Given this list of marker genes PPOX, DLL1, ATP1A3, SEMA3D, FXN, CYB561, SNAI2, AKAP9, RAD21, CPLANE1, NTRK1, SREBF1, TSPYL1, DNAJC6, CEP104, ARVCF, RFWD3, FANCG, LGI1, MMEL1, SMC1A, DBH, FOXH1, TNFSF15, BBS2 (NCBI Gene Id 583), MYO1H, FANCF, CAV1, DEPDC5, SLC6A8, UFD1, COL5A1, ERCC4, TBX1, KCNQ1, CCDC28B, RELN, SNCAIP, TGIF1, PINK1 (PTEN induced kinase 1), ALK, DHCR7, GNB2, PLA2G6, GAS1, BRIP1, SCN11A, WFS1, CEP41, ERBB2 (NCBI Gene Id 2064), TYR, HYLS1, RAD51, GABBR2, PAX3, LRRK2, ATXN2, TRIM32, GFAP, CYP11B2, TBX5, TXN2, SCN5A, CCT5, SUFU, PIGY, VPS11, CISD2, FGF8, MYCN, TOGARAM1, KCNH2, PODXL, IL12RB1, SMO, EDNRB, PIBF1, DDX3X, INPP5E, BBS7, BDNF, PIGL, SCLT1, TCTN3, BCOR, SH2B1, CRIPTO, SLC18A2, SPG11, IRF5, FANCI, CALM1 (calmodulin 1), FANCC, BRCA2, TTR, PLCH1, TMEM138, UBE2T, OFD1, SDCCAG8, KIT, TMEM237, MAD2L2, STAG2, COMT, RREB1, RPGRIP1L, SEMA3C, CDON, PRNP, PDE6D, ATXN3, ERBB3, EIF4G1, GSN, NPHP1, SAA1, SPTLC2, RET, CEP290, SOX10, L1CAM, SALL4, CHCHD2, TMEM67, PRKN, ATXN8OS, GBA1, ARL13B, ARX, LMO1, LZTFL1, IFT172, IL12A, TRDN, SEC24C, MAPT, KITLG, ZNF423, KIAA0753, LMNB1, SCN3A, TMEM218, RFC1, CACNA1C, PGAP3, CAV3, HEXB, APC2, POLR3A, KIF1B, FOXF1, ASCL1, NOS1AP, KCNJ5, AAAS, ADH1C, WDR45, MT-TT, ABCD1, DDX59, FBXO7, MBTPS2, IFT74, HACE1, SHH, CSPP1, TUBB3, BBS1, BBS9, KCNE1, TCTN1 (tectonic family member 1), GLI2, ECE1, PARK7, COQ2, SF3B4, HIRA, ARSA, EDN3, DISP1, SCN9A, B9D2, CFAP418, KIFBP, ATL1, FGFR1, GBE1, NODAL, ACBD6, ARL6, COL1A1, B9D1, SLC6A2, TUBA1A (tubulin alpha 1a), SYNE1, SLX4, NAA10, GDNF, PHOX2B, NR4A2, STIL, SETBP1, ATL3 (NCBI Gene Id 283241), CALM2, CACNA1A, JMJD1C, FANCB, SYNJ1, ACTG2, CEP120, PTCH1, FANCM, SLC1A3, BBIP1, PIGW, ELP1, KCNE2, SCN10A, CHRNA3, VPS35, SCN4B, BBS12 (NCBI Gene Id 166379), ANK2, ATP1A2, TMEM231, BBS5, TWNK, MKS1, CBY1, MECP2 (methyl-CpG binding protein 2), LBX1, FANCA, WDPCP (WD repeat containing planar cell polarity effector), GLA, LEP, SIX3 (NCBI Gene Id 6496), ZEB2, ACOX1, CALM3 (calmodulin 3), FANCE, TTC8, ARL3, TCF4, IFT27, CC2D2A, SNTA1, GP1BB, TBP, XRCC2, PIGV, RMRP, AHI1, NRTN, POU2AF1, SPTLC1, PIGO, PGAP2, GCK, GMPPA, KIAA0586, LIN28B, VPS13C, RAD51C, SPIB, LEPR, PALB2 (partner and localizer of BRCA2), ZIC2, CEP19, KATNIP, BRCA1, FANCD2, BRAT1, ATP7A, TCTN2, KRAS, SIM1 (NCBI Gene Id 6492), ATRX, FMR1, PIGN, ARMC9, VPS13A, MITF, B2M, GIGYF2, MKKS, FANCL, DNAJC13, PSAP, BBS4, TNPO3, SNCA, UCHL1, HTRA2, BBS10, SCAPER, CRELD1, LIFR, NSD1, COL5A2, TMEM216, here is a description of the gene set: Human Gene Set: HP_ABNORMALITY_OF_THE_AUTONOMIC_NERVOUS_SYSTEM Abnormality of the autonomic nervous system An abnormality of the autonomic nervous system. species: Homo sapiens